Given this list of marker genes SPINT1, HGF, SPINT2, HPN, HGFAC, MET, here is a description of the gene set: part of: Signaling by MET Reactome Pathway: MET Receptor Activation Hepatocyte growth factor (HGF), the ligand for MET receptor tyrosine kinase (RTK), is secreted into the extracellular matrix (ECM) as an inactive single chain precursor (pro-HGF). The biologically active HGF is the heterodimer of alpha and beta chains that are produced via proteolytic cleavage of pro-HGF by the plasma membrane bound serine protease Hepsin (HPN) or the ECM-associated serine protease Hepatocyte growth factor activator (HGFAC, commonly known as HGFA). HGF binds to the extracellular SEMA and PSI domains of MET RTK, inducing a conformational change that enables MET dimerization or oligomerization. MET dimers trans-autophosphorylate on tyrosine residues in the activation loop, leading to increased kinase activity, and on tyrosine residues at the cytoplasmic tail that serve as docking sites for adapter proteins involved in MET signal transduction.<br>CD44v6 was implicated as a MET co-receptor, but its role has been disputed. species: Homo sapiens